Given this list of marker genes Afp, Stard3, Srd5a1, Dhrs9, Akr1cl, Hsd3b9 (hydroxy-delta-5-steroid dehydrogenase, 3 beta- and steroid delta-isomerase 9), Akr1c6, Cyp46a1, Cyp17a1, Akr1c20, Cyp21a1, Egr1 (NCBI Gene Id 13653), Stat5b, Akr1c18, Scp2, Akr1c21, Hsd3b4, Akr1c19, Dgkq, Akr1c12, Hsd3b8 (hydroxy-delta-5-steroid dehydrogenase, 3 beta- and steroid delta-isomerase 8), Ppargc1a, Hsd3b5, Akr1c13, Akr1c14, here is a description of the gene set: studied in species Mus musculus Mouse Gene Set: GOBP_PROGESTERONE_METABOLIC_PROCESS The chemical reactions and pathways involving progesterone, a steroid hormone produced in the ovary which prepares and maintains the uterus for pregnancy. Also found in plants.